The following is a description of a gene set: studied in species Mus musculus Mouse Gene Set: GOBP_NON_PROTEINOGENIC_AMINO_ACID_METABOLIC_PROCESS The chemical reactions and pathways involving non-proteingenic amino acids., and this is the list of marker genes: Gad1, P4hb (prolyl 4-hydroxylase, beta polypeptide), Atp2b4, Htt, Abat, Dao, Aldh6a1, Arg1, Ero1a, Hoga1, Gad2, Slc1a3, Aldh1a1, Azin2, Pcmt1, Pemt, Cad, Ahcyl, Park7, Aldh5a1, Gamt, Blmh, Upb1, Oaz1, Icmt, Dpys, Dpep1, Dpyd (dihydropyrimidine dehydrogenase), Kyat3, Cbs (NCBI Gene Id 224676), Srr, Prdx4, Ido2, Agxt2 (alanine-glyoxylate aminotransferase 2), Crtap, Mthfd1, Kyat1, Aldh8a1, Mthfr, Ero1b, Ddah1, Otc, Arg2, Tdo2, Asl, Mmut, Comt, Ahcy, Mpst, Aldh18a1, Aadat, Slc38a1, Kynu, Slc25a2, Ido1, Kmo, Cps1, Sardh, Ddo, Mtr, Gnmt, Plod2, Mtrr, Plod3, Aasdh, Egln2, Cth, Hnf4a, P4ha2, P4ha1, Phgdh, Nox4, Afmid, Ass1